Given this list of marker genes DCUN1D1, DCUN1D5 (defective in cullin neddylation 1 domain containing 5), DCUN1D2, DCUN1D4, DCUN1D3, here is a description of the gene set: studied in species Homo sapiens Human Gene Set: GOBP_POSITIVE_REGULATION_OF_PROTEIN_NEDDYLATION Any process that activates or increases the frequency, rate or extent of protein neddylation.